Given this list of marker genes Ptpn6, Cd177, Plpp6, Syk, Lypd10, Ccl5 (NCBI Gene Id 20304), Fcer1g, Anxa3 (annexin A3), Il18, Itgb2l, Kmt2e, Ctsg, Cxcr2, Itgb2, Anxa1, Abr, F2rl1, Il15, Itgam, Clec12a, Spi1, Ptafr, Dnase1l3, Prkcd, Traf3ip2, Prg3, Pla2g2a, Stxbp3, Dnase1, Scnn1b, Il18rap, Tnf, Stx11, Gkn2, Tyrobp, Il16, Bcr, Cxcl5, Myd88, Myo1f, Cd300a, Pram1, Ptpn11, Camp (cathelicidin antimicrobial peptide), Fcgr4, Pikfyve, Lypd11, Src, Grn, here is a description of the gene set: Mouse Gene Set: GOBP_NEUTROPHIL_ACTIVATION The change in morphology and behavior of a neutrophil resulting from exposure to a cytokine, chemokine, cellular ligand, or soluble factor. studied in species Mus musculus